The following is a description of a gene set: Human Gene Set: HP_HYPERLEUCINEMIA Hyperleucinemia An increased concentration of leucine in the blood. studied in species Homo sapiens, and this is the list of marker genes: BCAT2, MCCC2, ATP5F1B, PPM1K, BCKDHB